Given this list of marker genes KCND3, KCNK13, KCNA5, KCNK12, KCNK16, KCNK10, KCNK6, KCNIP2, PKD2 (NCBI Gene Id 5311), KCNB1, KCNT2, KCNK18, KCND2, KCNQ1, KCNK17 (potassium two pore domain channel subfamily K member 17), KCNA2, KCNK2, KCNK9, KCND1, KCNK4, KCNK7, KCNK3, KCNT1, KCNK5, here is a description of the gene set: Enables the transmembrane transfer of a potassium ion by an outwardly-rectifying voltage-gated channel. An outwardly rectifying current-voltage relation is one where at any given driving force the outward flow of K+ ions exceeds the inward flow for the opposite driving force. species: Homo sapiens Human Gene Set: GOMF_OUTWARD_RECTIFIER_POTASSIUM_CHANNEL_ACTIVITY